Given this list of marker genes Ereg, Gas2, Pla2g4a, Lep, Afp, Inhbb, Foxo3, Sirt1, Pde4d, Immp2l, Edn2, Agt, Oas1d, Adamts1, Kmt2b, Mmp19, Nos3, Mmp2, Pgr, Nos2, Alms1, Inhba, Nrip1, Hpgd, Gpr149, here is a description of the gene set: studied in species Mus musculus Mouse Gene Set: GOBP_OVULATION The release of a mature ovum/oocyte from an ovary.